The following is a description of a gene set: Hyperactivity is a condition characterized by constant and unusually high levels of activity, even in situations where it is deemed inappropriate. species: Homo sapiens Hyperactivity Human Gene Set: HP_HYPERACTIVITY, and this is the list of marker genes: CNTNAP2, NTRK1, TPH2, ASL, HEPACAM, CACNA1H, UPF3B, SMARCA4, CUL3, PMS1, GABRA1, FOXH1, SMARCE1 (SWI/SNF related, matrix associated, actin dependent regulator of chromatin, subfamily e, member 1), CLCN3, ARID1A, CARS1, CUL4B, DLL1, SPRED1, SYNGAP1, ANKRD17, NSD2 (nuclear receptor binding SET domain protein 2), CNKSR2, STX1A, GABRA2, ODC1, TBL2, CHRNA7, POGZ, NKAP, PRNP, MAGEL2 (MAGE family member L2), DDB1, GAS1 (NCBI Gene Id 2619), ZDHHC9, CLIP2, HUWE1, WDR62, ASCC3, LIG4, SMPD1, PRR12, GTF2IRD2, PANK2, MKRN3, EPCAM, IQSEC1, NECAP1, TSC1, GABRB2, GNS, FLI1, ATP6V1A, P2RY11 (purinergic receptor P2Y11), DRD5, NAA60, GABBR1, CCBE1, SLC13A5, CDH11, THRB, STEEP1, TANC2, ATP1A1, KDM5C, PLCH1, CHKA, AARS1, GNAO1, KAT8 (NCBI Gene Id 88034), SCN2A, HLA-DQB1, METTL27, MED13L, CUX2, CRBN, SLC25A13, AFF2, ARID1B, GRIK2, PPP1R21, CACNA1C, EIF4A2 (eukaryotic translation initiation factor 4A2), GNB1, HNRNPH2, TKT, PNKP, ALG14, TRIM8, KCNN2, MBD5, RSRC1, PPP2R1A, NR2F1, ZNF365, PRKCG, ARID2, STS, RREB1, TTI2, ANAPC1, NEXMIF, IL1RAPL1, SETD5, PPP3CA, ATP10A, TBX2, TSHB, NAGLU, BUD23, NPAP1, TMEM270, FGFR3 (fibroblast growth factor receptor 3), CTSH, GLDC, NIPA1, OCA2, ZSWIM6, GATAD2B, SZT2, CORO1A, SMC3, CAMTA1, ADGRL1, ATM (ATM serine/threonine kinase), LNPK, NDP, NTNG2, MCTP2, CELF2, NLGN1, KIF11, SCN1B, NIPA2, PLAG1, TUBG1, PDCD6IP, PIGQ, SMARCB1, KPNA3, GCSH, CHRNA4, HDAC4, FANCL, STAG2, IGF2, LIMK1, INPP5E, TUBB3, FLG, SCAPER, JMJD1C (NCBI Gene Id 9323), FERRY3, VPS37D, CRKL, DRD4, ZMYM3, MTOR, NSUN6, UBA5, GALT, NOP56, DPH1, BBS2, HIVEP2, KCNA4, EIF4H, GRIN1, ALDH5A1, HDAC8, GLUD1, PARS2, WWOX (NCBI Gene Id 9621), NODAL, ASH1L, MLH1, CDKL5, SLC9A7, PIGP, UBTF, PUF60 (poly(U) binding splicing factor 60), TGFBR2, GRM7, DYRK1A, HIRA, MANBA, FLCN, PPP2CA, ASPM, TRIO, MED13, SEMA3E, CDK10, NIPBL, SLC6A1, PTEN, CACNA1B, RAC1, DHDDS, COMT, SLC25A22, SHMT2, DENND5A, POLE, PAH (NCBI Gene Id 5053), MICU1, MSH6, PTCH1, ANK3, PHF21A, GNAQ, TBC1D2B, DHTKD1, CHD7, DPP6, AUTS2, YME1L1, PWAR1, SH2B1, WBP11, SMC1A, RFX7, TMCO1, GNB5, ANKRD11, BSCL2, ATP1A3, TMEM67, PDZD8, AGO2, SH3KBP1, TNPO2, DDX3X, PWRN1, ACY1 (NCBI Gene Id 95), UBAP2L, LGI3, GLRA2, TUBB2B, CRH, ZMIZ1, GAMT, SOX6, PHIP, KIF14, PSMB1, NSD1, GP1BB, CHD3, CACNA1A, ARVCF, FOXG1, POLD1, H3-3A, SOX11, GATA4, TAF1, EBP, GNE (NCBI Gene Id 81868), USP7, DCDC2, PAK3, FGD1, PCGF2, ADSL, ELN, CASK, GABRB3, CYP27A1, IKBKG, CHRNA2, FMR1, HDC, KMT5B, SLC32A1, IVD, SLC38A3, YY1, SRPX2, ARX, ATP6V0A1, DPYS, PDE4D, TTI1, CHD5, ADNP, TIAM1, NEUROD2, KANSL1, TRAPPC9, MAP1B, PNP, APC2, VPS13A, BCORL1 (NCBI Gene Id 93949), RUSC2, SPTBN1, NCF1, HNRNPR, DNAJC30, BCR, AP1G1, SLC6A19, SNRPN, LHCGR, CSNK2A1, CHRNB2, EBF3, SNORD116-1, KDM3B, FOXP1, NBEA, OPHN1, MRPL39 (NCBI Gene Id 64977), FGF8, KMT2B, AQP4, RAB39B, BCAP31 (B cell receptor associated protein 31), DYM, MUTYH, GRIN2D, SIM1, AASS, CHD8, PCNT, KCNB1, MED12L, MID2, DHCR7, CACNA2D1, SMARCD1, PMS2, BRD4, NSUN2, SHOC2, DPH2, KRAS, KCNK9, FRMPD4, FZR1, HMGA2, ALKBH8, FLII, CASP2 (NCBI Gene Id 835), KMT2A, PRODH, SYNJ1, SLITRK2, SMAD4, HLA-DRB1, PRKD1, MADD, ADH5, NF1, SOX4, DPYD, LMAN2L, CDK19, TNFSF4, SLC1A4, HNRNPK, ZBTB20, TCF20, IGF1, KCNA2, DYNC1I2, HGSNAT, SRCAP, KDM4B, MOG, SCN1A, PPP1R12A, BCKDK, YWHAG, HCN1, KCNC2, NUS1, AP2M1, SLC4A10, METTL5, PRKAR1B, TBC1D23, PDGFRB, FANCD2, ZMYM2, TSC2, ZFX, CDH2, RAD21, FOXP2, AGO1, SCN3A (NCBI Gene Id 6328), ARG1, DMPK, UFD1, SOX5, MAB21L1, TGIF1, FGF12, WAC, JARID2, GABBR2, WBP4, TSHR, MSH2, PLA2G6, EP300, SEC24C, AHDC1, CDK8, CSGALNACT1, GRIN2A, EHMT1 (NCBI Gene Id 79813), TIMM8A (translocase of inner mitochondrial membrane 8A), DNAJC21, GABRA5, CTCF, MED12, UBE4A, DPF2, ARPC4, HAL, PIDD1, IFNG, ACTL6B, TRAPPC14, SHH (NCBI Gene Id 6469), SPTAN1, MECP2, SLC6A8 (NCBI Gene Id 6535), MAPK10, NFIB, SIX3, FKBP6, SMARCA2, DLG3, SPG7, DEPDC5, RPS20, MYT1L, IQSEC2, GTF2I, UBE3A, ATRX, TNRC6B, CYFIP2, NKX2-1, TAF6, JRK, GLI2, UQCC2, BAP1, ZIC2, TRIP12, GABRG2, H4C5, DMXL2, EIF2AK1, RERE, NBN, SLITRK1, KIF15, GTF2IRD1, RAI1, CRIPTO, GALC, BRCA2, FBXO11, ZNF292 (zinc finger protein 292), HCRT, BMPR1A, NFIA, CABP4 (calcium binding protein 4), KCNT1, DNAJC12, SEMA4A, SCN8A, RFC2, HTT, KCNA1, KDM6B, DEAF1, FGFR1, SGSH, TMEM222, ATP1A2, SMARCC2, CLTC, NAA15, CDC42BPB, UBE3C, PIEZO2, KAT5, FBXO28, HERC2, MAPK1, TNIK, OTC, PTCHD1, ATP9A, CHEK2, CLCN4 (chloride voltage-gated channel 4), SPR (sepiapterin reductase), DALRD3, TUBA1A, SLC25A36, DISP1, STXBP1, HOXA2, TRAK1, GRIA1, SATB2, SHROOM4, ADAT3, SIN3A, TET3, SUPT16H, TLK2, SLF2, SIK1 (salt inducible kinase 1), PUS7, CC2D1A, RIC1, NSDHL, NFIX, CDKN1C, TBL1X, CDON, MLXIPL, PIK3CA, CHD2, TBX1, ABCD1, CIC, SHANK3, SMC5, CREBBP, CAPRIN1, SRRM2, SLC2A1, NTRK2, SPEN, TMEM147, AP3B2, PCDH19 (NCBI Gene Id 89774), SLC7A6OS, STIL, EEF1A2 (NCBI Gene Id 6669), SLC1A2, SETBP1, HSPG2, ATR, PPM1D, TAOK1, PACS2, BAZ1B, KCNH5, SNORD115-1, OCRL, DNM1, POLA1 (DNA polymerase alpha 1, catalytic subunit)